Given this list of marker genes ECHS1, ACADS, ALDH6A1, ACADM, HADHA, ACAD8, HIBADH, HIBCH, here is a description of the gene set: species: Homo sapiens Human Gene Set: KEGG_MEDICUS_REFERENCE_VALINE_DEGRADATION Pathway Definition from KEGG: IB-CoA -- (ACADS,ACAD8,ACADM) >> (ECHS1,HADHA) >> HIBCH >> HIBADH >> ALDH6A1 -> Propanoyl-CoA Valine degradation. Pathway ID: N00852. Pathway type: Reference. Pathway class: nt06024 Valine, leucine and isoleucine degradation.